Given this list of marker genes H2AC20, H2AJ, H2BC15 (H2B clustered histone 15), H3-4, H2AC18, OGG1, H2BC4, ACD, H2AC14, H2AZ2, H2AX, H2BC1, H2BC11 (H2B clustered histone 11), H2BC26, H2AC4, H4C1, MUTYH, H2BC9, H2BC12L, NEIL3, POT1, TINF2, H2BC14, MPG, TERF2IP, H2BC5, H2AC7, TERF2, H2BC17, H2BC3, H2AC6, H2AB1, H2BC13, TERF1, H2BC12, H2BC21, here is a description of the gene set: part of: Base-Excision Repair, AP Site Formation Depurination of a damaged nucleotide is mediated by a purine-specific DNA glycosylase. The glycosylase cleaves the N-C1' glycosidic bond between the damaged DNA base and the deoxyribose sugar, generating a free base and an abasic i.e. apurinic/apyrimidinic (AP) site. studied in species Homo sapiens Reactome Pathway: Depurination